Given this list of marker genes EPHA8, SCARF1, APP, NTN4, KCNQ3, C3, C1QL1, C1QA (complement C1q A chain), RND1, ADGRB3, EDNRA, FARP2, CX3CL1, BCL11A (NCBI Gene Id 55085), ANKS1A, here is a description of the gene set: studied in species Homo sapiens The developmentally regulated remodeling of neuronal projections such as pruning to eliminate the extra dendrites and axons projections set up in early stages of nervous system development. Human Gene Set: GOBP_NEURON_REMODELING